The following is a description of a gene set: from publication He P, Lim K, Sun D, Pett JP, Jeng Q, Polanski K, Dong Z, Bolt L, Richardson L, Mamanova L, Dabrowska M, Wilbrey-Clark A, Madissoon E, Tuong ZK, Dann E, Suo C, Goh I, Yoshida M, Nikolić MZ, Janes SM, He X, Barker RA, Teichmann SA, Marioni JC, Meyer KB, Rawlins EL (PMID 36493756) studied in species Homo sapiens Schwann precursor Human Gene Set: HE_LIM_SUN_FETAL_LUNG_C7_SCHWANN_PRECURSOR_CELL, and this is the list of marker genes: CCDC18, SPAG5, SCRG1, CENPA, CDCA5, MTERF3 (NCBI Gene Id 51001), CCNB1, CHEK1, REEP4, CDC6, SPC25, DEPDC1, ORC6, GLI3, STXBP6, CENPU, POSTN, CTH, FANCI, SNTB1, FEN1, RRS1, CLSPN, TP53, CDK1, DNAJA4, VRK1, LRR1, SGO1, FZD1, WDHD1, ZWINT, INSC, PRSS56, ITGA4, DIAPH1, RNF157, CRB1, DNAAF5, NPR3, UHRF1, RNASEH2A, MCM4, TAC1, H2AC20, HEYL, MXD3, ADAM12, RFC4, TPD52L1, MCM3, MTAP, CCDC34, RTKN2, NCAPG, TOP2A, CDKN3, TIMELESS, PPIF, CDCA2, SFRP2, TROAP, CCNB2, WEE1, ECT2, H2AC13, CENPK, CDCA7L, TPX2, ENC1, H3C2, NET1, KNL1, NOTCH1, DIAPH3, GINS2, GMNN, TRIP13, CDC20, RACGAP1, NCAPD2, SVIP, UBE2C, AIRIM, EYA1, CENPM, BAG3, KCNK2, SMC2, LYAR, TYMS, BCAR3, KIF23, CMTM7, ELK3, HJURP, IER5 (immediate early response 5), CENPO, HELLS, BARD1, KIF4A, CDT1, FLRT1, RUBCNL, EMILIN1, UBE2T (NCBI Gene Id 29089), CRYM, PIMREG, NDE1, DNAJB4, ASPM, H1-1, MCM2, CENPN, PSRC1, GGA2, TNFRSF19, ITGB3BP, CHAF1A, CENPH, LHFPL2, YAP1, SPC24, LRP5, BUB1, TK1, PCNA, DHFR, FAM83D, TRIM9, CKAP2, GJC1, TGFB2, CCNA2, KDR, CDCA7, YBX3, SLC16A1, PBK, SLC1A5, NCAPH, ANLN, CDCA3, KIF11 (NCBI Gene Id 3832, kinesin family member 11), MDFIC, INCENP, MGST1, EZH2, SGO2, PRIM2, TFAP2B, KIF2C, NUSAP1, ERBB4, FOXM1, FILIP1L, PARPBP, KIF20B, MCM6, MYBL2, CKAP2L, RMI2, PTTG1, MIS18A, HSPA6, E2F1, CDCA8, MKI67, GTSE1, CENPE, TCF7L1, RBM38, H2AC11 (NCBI Gene Id 8969), SLC15A3, KIF16B, TMEM51, KIF20A, MAD2L1, BIRC5, DBF4, CDCA4, H2AC14, CENPF, ARAP2, H1-5, POC1A, NOX4, TACC3, MNS1, PHF19, OAF, RAD51AP1, ADGRG6, BCAT1 (NCBI Gene Id 586), KIF15, POLA2, ANP32E, KIFC1, RLBP1, PKMYT1, MND1, BCL2L12, ATAD5, CENPW, MIS18BP1, MELK, CCDC117, NDC80, SUV39H2, IMPA2, PLK1, MYO10, AURKB, CDK2, PHLDB2, FOXP2, CIP2A, ATAD2, HOOK1, CALCB, CCN2, H2BC9, NUF2, DLGAP5, PCSK5, FBXO5, MAFF, EFCAB11, GGCT (gamma-glutamylcyclotransferase), DEPDC1B, LINC01198, ASF1B